The following is a description of a gene set: studied in species Mus musculus electronically inferred by orthology from the curated human pathway Reactome Pathway: ADP signalling through P2Y purinoceptor 1 This event has been computationally inferred from an event that has been demonstrated in another species.<p>The inference is based on the homology mapping from PANTHER. Briefly, reactions for which all involved PhysicalEntities (in input, output and catalyst) have a mapped orthologue/paralogue (for complexes at least 75% of components must have a mapping) are inferred to the other species. part of: Signal amplification, and this is the list of marker genes: Gng3, Gng8, Gng10, Gngt1, Gng7, Gng4, Gngt2, Mapk14, Gna14, Gnb3, Gng11, P2ry1, Gng5, Gnb5, Gnb2